The following is a description of a gene set: Mouse Gene Set: GOCC_90S_PRERIBOSOME A large ribonucleoprotein complex considered to be the earliest preribosomal complex. In S. cerevisiae, it has a size of 90S and consists of the 35S pre-rRNA, early-associating ribosomal proteins most of which are part of the small ribosomal subunit, the U3 snoRNA and associated proteins. studied in species Mus musculus, and this is the list of marker genes: Utp20, Kri1, Utp6, Tbl3, Srfbp1, Wdr12, Bop1, Wdr36, Noc4l, Pes1, Nop14, Nol6, Slx9, Utp18, Casp8, Rrp7a, Nop9, Heatr1, Imp3, Imp4, Mphosph10, Pwp2, Noc2l, Wdr3, Utp4, Rrp36